The following is a description of a gene set: Punctate palmoplantar hyperkeratosis species: Homo sapiens Human Gene Set: HP_PUNCTATE_PALMOPLANTAR_HYPERKERATOSIS, and this is the list of marker genes: AAGAB, CAST, KRT5, ENPP1, ATP2A2, KRT14